The following is a description of a gene set: species: Mus musculus Catalysis of the reaction: S-adenosyl-L-methionine + guanosine in tRNA = S-adenosyl-L-homocysteine + tRNA containing methylguanine. Mouse Gene Set: GOMF_TRNA_GUANINE_METHYLTRANSFERASE_ACTIVITY, and this is the list of marker genes: Trmt10a, Trmt1l, Trmt10b, Trmt5, Thumpd3, Tarbp1, Thumpd2, Trmt10c, Trmt1, Ftsj1, Trmt11, Mettl1